Given this list of marker genes MORC1, TDRD9, SMYD5, C19orf84, TDRD12 (NCBI Gene Id 91646), PIWIL4, MORC2, DNMT3A, PIWIL2, SPOCD1, MAEL, MOV10L1, RESF1, FKBP6, PIWIL1, TDRD5, TASOR, TDRD1, MPHOSPH8, SPIN1, DNMT3L, SETDB1, DDX4 (DEAD-box helicase 4), here is a description of the gene set: A transposable element silencing mechanism involving heterochromatin assembly. Heterochromatin is a chromatin conformation that is refractory to transcription. Human Gene Set: GOBP_TRANSPOSABLE_ELEMENT_SILENCING_BY_HETEROCHROMATIN_FORMATION studied in species Homo sapiens